The following is a description of a gene set: Any process that decreases the rate, frequency, or extent of cartilage development, the process whose specific outcome is the progression of the cartilage over time, from its formation to the mature structure. Cartilage is a connective tissue dominated by extracellular matrix containing collagen type II and large amounts of proteoglycan, particularly chondroitin sulfate. species: Mus musculus Mouse Gene Set: GOBP_NEGATIVE_REGULATION_OF_CARTILAGE_DEVELOPMENT, and this is the list of marker genes: Grem1, Efemp1, Adamts7, Gdf5 (NCBI Gene Id 228821), Snai2, Idua, Ihh, Nr5a2, Tgfbr1, Adamts12, Tgfb2, Ptpn11, Gli2, Rarb, Ltbp3, Frzb, Rara, Nog, Gli3, Ctnnb1, Chadl, Bmp4, Lep, Pth, Ctsk, Wnt9a, Pthlh, Rflnb, Ccn4, Nkx3-2, Rflna, Mkx, Rarg, Sox9